The following is a description of a gene set: studied in species Homo sapiens In sickle cell disease, deoxygenation of intra-erythrocytic hemoglobin S leads to hemoglobin polymerization, erythrocyte rigidity, hemolysis, and microvascular occlusion. Ischemia-reperfusion injury, plasma hemoglobin-mediated nitric oxide consumption, and free radical generation activate systemic inflammatory responses. To characterize the role of circulating leukocytes in sickle cell pathogenesis we performed global transcriptional analysis of blood mononuclear cells from 27 patients in steady-state sickle cell disease (10 patients treated and 17 patients untreated with hydroxyurea) compared with 13 control subjects. We used gender-specific gene expression to validate human microarray experiments. Patients with sickle cell disease demonstrated differential gene expression of genes involved in heme metabolism, cell-cycle regulation, antioxidant and stress responses, inflammation, and angiogenesis. Inducible heme oxygenase-1 and downstream proteins biliverdin reductase and p21, a cyclin-dependent kinase, were up-regulated, potentially contributing to phenotypic heterogeneity and absence of atherosclerosis in patients with sickle cell disease despite endothelial dysfunction and vascular inflammation. Hydroxyurea therapy did not significantly affect leukocyte gene expression, suggesting that such therapy has limited direct anti-inflammatory activity beyond leukoreduction. Global transcriptional analysis of circulating leukocytes highlights the intense oxidant and inflammatory nature of steady-state sickle cell disease and provides insight into the broad compensatory responses to vascular injury. from publication Jison ML, Munson PJ, Barb JJ, Suffredini AF, Talwar S, Logun C, Raghavachari N, Beigel JH, Shelhamer JH, Danner RL, Gladwin MT (PMID 15031206) Human Gene Set: JISON_SICKLE_CELL_DISEASE_DN Genes down-regulated in peripheral blood mononuclear cells (PBMC) from sickle cell disease patients compared to those from healthy subjects., and this is the list of marker genes: MSMB, EIF3D (NCBI Gene Id 8664), PTPRM, SARAF, MSL1, BTF3, COX6C, DYRK2, ASB9, EEF1B2, IMPDH2, RBBP6 (NCBI Gene Id 84712), CCSER2, BCLAF1 (NCBI Gene Id 9774), NACA, SRSF8, RPL5, COX11, RPS24, IPCEF1, RPL21, AMY1A, CEP68, ARHGEF7, DDX5, EIF3K, FAN1, RPL11, ATRX, MCF2L, HNRNPH1, RNF44, TSC22D3, ANP32B, TXNIP, RPL14, SRP19, MYOM2, RPS13, SNRNP70, CCR7, ZNF211, VPS13A, RPL6, RPL17, RPL22, SRSF2, RPL30, RPS7, ZNF710-AS1, PDE3B, RPL13A, HERC2P9, SMC5, ERCC5, PMM1, ERCC3, RPS6, MAPK8IP1, NONO, FGF9, SLC25A6, RBL2 (RB transcriptional corepressor like 2), NAP1L1, EEF1G, AP1G2, RPLP0, ZNF354A, FNBP4, PRRC2C, COBLL1, OTUD3, EEF2, POLR2H, RPL23A (ribosomal protein L23a), FAM153A, KLRK1, OTUD4, TLE5, RPL37, TGFB1, NSUN5P1, NELL2, DUSP2, GLS, RPL24, ESR1, OGT, MID2, RPL41, PTMA, POLG, CSNK1E, ITGAD, PNMT, TRIM32, DGKA, EIF3E, PKP3, HNRNPDL, MSH2, TBC1D4, RPL9P7, SAFB2 (NCBI Gene Id 9667), GPR183, TRAF5, CDX2, PFN2, SLC4A7, ITPKB, RFC4, FAM168B, LINC01278, CDK10, SATB1, GPATCH8, EIF4A2, HSPA8, BBIP1, ATP6V0E2, SNRNP200, BTG1, TOP2B (NCBI Gene Id 7155), RASGRP2, FBL, RAP1GAP2, TCF3, HLCS, RUNX3, CELSR3, SUGP2, RNF126, RPS27A, EIF3F, EIF3H, FOXJ3, RPL13, SET, VPS52, EIF4A1, GPX3, SPECC1L, TMC6, ARHGEF18, PABPC4, METTL18, NPM1, ZNF384, ATXN2L, RPL19, RPL4, KLF9, SFPQ, MMP3, TMED10, TRAF3IP3, PRICKLE3, BRD1, JAK1, ATM, MZF1, B4GAT1 (NCBI Gene Id 11041), MICA, RPS20, SRSF6, SAP25, EEF1A1, SETD2, FYN, SRRT (NCBI Gene Id 51593), TOMM7, RPS28, TUT4, RPL10A, CIRBP, RPLP1, RPL7 (NCBI Gene Id 6129), LPAR2 (lysophosphatidic acid receptor 2), CXCR4, ITPR3, GANAB, SRSF5, EEIG1, UNG, EIF4B, USP9X